The following is a description of a gene set: Human Gene Set: HP_DEHYDRATION studied in species Homo sapiens Dehydration, and this is the list of marker genes: GATM, LAMB3, TGFB1, ATP1A2, CYP11A1, CLCNKB, PCCB, MYO5B, TCF3, STX3, SLC5A1 (solute carrier family 5 member 1), SLC12A1, CD79A, EGFR, VPS33B, SDR9C7, SPINK5, ABCA12, CDKN1B, HMGCL, LRRC8A, MEN1, SLC22A5 (NCBI Gene Id 6584), EPCAM, SPI1, ACAD8, UNC45A, ALOX12B, CA12, IGHM, HYMAI, EIF2AK3, EHHADH, NLRP3, CDKN1A, CYP24A1, NR0B1, SULT2B1, CD79B, SLC1A3, DBH, CACNA1A, SLC34A1, CDKN2C, NARS2, PCCA, LAMC2, CFTR, SLC5A2, MMACHC, AVPR2, MMAA, PKHD1, LIPN, OCRL, AK2, MMAB, ACSF3, PERCC1, CLMP, ATP6V0A4, FCGR2A, AQP2, MRPS28, ABCC8, GCK, BLNK, CDKN2B, CLPB, SLC39A7, NR3C2, INS, KRT10, SLC26A3, ASPRV1, IGLL1, CYP4F22, MCEE (methylmalonyl-CoA epimerase), MPV17, LAMA3, CYC1, STAT3, HSD3B2, LCT, MMUT (NCBI Gene Id 4594), ALOXE3, SCNN1G, IVD, NIPAL4, ZFP57, SCNN1B, AGXT, CLCNKA, SCNN1A, CTNS, PDX1 (pancreatic and duodenal homeobox 1), NEUROG3, PIK3R1, NDUFAF6, KCNJ1, KCNJ11, TGM1, BSND, ATP1A3, ERCC6, ACAT1, PLAGL1, CYP11B2